Given this list of marker genes MX1, DDX52, TOX, BST2 (NCBI Gene Id 684), CASP4, TNFRSF25, CCND2, EFEMP2, KCND1, STAT3, EDN1, DOCK9, FLAD1, PRDM2, TRADD, RWDD3, CALCOCO2, SP110, SLAMF7, STAT5A, GPR171, IFI6 (NCBI Gene Id 2537), ADAR, C11orf68, REEP2 (receptor accessory protein 2), MTUS1, RGS3, DYNLT1, LPIN2, NFKB2, RPS5 (ribosomal protein S5), RIPK1, MT1H, MICB, IPCEF1, SETX, PARP3, UBA52, BTN3A3, SFMBT1, CSF1, CREM, TPR, LTA, AFF2, COLQ, PHF11, SYNE2, MT1F, ZNF516, RAB3GAP1, POLR1G, MX2, GTPBP8, WDFY3, N4BP2L2, MT1G, TMEM140 (transmembrane protein 140), TRANK1, GBP1, TAF7, XAF1, GIMAP6 (GTPase, IMAP family member 6), ISG20, PLAAT4 (phospholipase A and acyltransferase 4), IDO1, TREM1, CMTR1, CSGALNACT1, PSMB10, ARID5B, RERE, PDK3, IFI44L, IRF7, RBCK1, STN1, CNP (2',3'-cyclic nucleotide 3' phosphodiesterase), BTN3A2, STOM, MSC, IFITM1, PUS3, TP53TG1, SMCHD1, ZNF148 (zinc finger protein 148), CCDC88C, APOL2, PSME1, STAM2, VPS51, MT1X (metallothionein 1X), IFITM2, APOL1, RSAD2, IFIT2, RNF114, ANKRD6, ORM1, PCDHGB6, GNB5, SP100, TRPM1, NARF, HERC6 (HECT and RLD domain containing E3 ubiquitin protein ligase family member 6), HHLA1, ATRNL1, ZC3H12A, MIA3, GRK5, ARL4A, APOL3, BTN3A1, PARP12, OPTN, GZMB, SLC50A1, HERC5, SSX1, RABGAP1L, THUMPD1, OCEL1 (occludin/ELL domain containing 1), OR1F1, DGLUCY, LYRM2, DKK2, BATF, INHBA, MT2A, LCT, MAN1C1, PTPRCAP, ALOX5AP, RPGR, PLPP1, SLC6A12, THRB, PTPRB, IFIT3, TRIM21, RPL28, SLC20A2, RALB, ZSCAN16, UBE2L6, CD2, KIR3DL3, TRHDE, AIP, TRAC, CIR1, HAUS3, CD96, JAKMIP2, CLUAP1, HIF1A, FOLH1, ASB8, ADGRE5, DDX60, GUK1, GIMAP5, PFKFB1, BAG3, GBP2, B4GALT4, HLA-F, G3BP2, EIF2AK2, RBKS (ribokinase), LEPR, GK, TREX1, OAS2 (NCBI Gene Id 4939), TBPL1, TAP1, IFIT5, PTPN2, ZNF22, CFB, HBEGF (heparin binding EGF like growth factor), NEMP1, SH3TC2 (SH3 domain and tetratricopeptide repeats 2), NEK11, SPHK1, F3, TAGLN3, CGGBP1, ANK3, STX17, TRIM22, KNG1, MED25, TLE4, VAMP5, EXOC2, SP140, IFNA7, PSMB9 (proteasome 20S subunit beta 9), here is a description of the gene set: from publication Prots I, Skapenko A, Lipsky PE, Schulze-Koops H (PMID 21347372) Genes down-regulated in comparison of CD25- T cells treated with IL4 at day 5 versus untreated CD25- T cells at day 5. CD25+ regulatory T cells develop in the thymus (nTregs), but may also be generated in the periphery upon stimulation of naive CD4 T cells under appropriate conditions (iTregs). The mechanisms that regulate the generation of peripheral iTregs are largely unknown. We used microarrays to gain insights into the molecular program of extrathymic Treg development. Human Gene Set: GSE24634_IL4_VS_CTRL_TREATED_NAIVE_CD4_TCELL_DAY5_DN species: Homo sapiens